The following is a description of a gene set: species: Mus musculus from publication Chen Y, Wang X (PMID 31504780) Genes predicted to be targets of miRBase v22 microRNA mmu_miR_107_5p in miRDB v6.0 with MirTarget v4 prediction scores > 80 (high confidence targets). Mouse Gene Set: MIR_107_5P, and this is the list of marker genes: Wsb1, Dipk2b, Naa30, Dusp3, Dolk, Alkal1, Fam120b, Cux1, Tada2b, Vps29, Phaf1, Tacr2, Slc6a15, Bbs10, Dyrk1a, Mtr, Cyld, Mtch2, Bmi1, Pwwp2a, Rgl1, Mysm1, Sigmar1, Ngef, Dnm3, Pitpnm2, Slc15a2, Lurap1l, Tbx2, Rspo3, Mctp2, Cdh11, Samd3, Mbnl2, Dach1, Gab2, Ginm1, Zbtb5, Pnma8b, Atrn, Tnpo1, Plcxd2, Ash1l, Gclm, Cdadc1 (NCBI Gene Id 71891), Rnpc3, Ammecr1, Ptprr, Cab39l, Cyct, Nr3c1 (nuclear receptor subfamily 3, group C, member 1), Stra6l, B230219D22Rik, St8sia3, Fam174a, Arsa, Itm2b, Grm7, Hccs, Ica1l, Dlc1, Rbm27, Bbx, Klhl24, Lipa, Prkaa2, Rcn1, Zbtb24, Ing5, Cdh12, Smarca4, Gpr82, Mab21l2 (NCBI Gene Id 23937), Micu3, Rala, Zfp827, Taf12, Pdzd2, Usp31, Rps15a, Man2a1, Mtmr1, Slc8a1, Ndst3, Thumpd3, Mef2c, Tmx2, Ankrd13b, Stx17, Hnrnpa2b1, Cbx6, Trak1, Nedd4l, Sec23ip, 1700066M21Rik, Tardbp, Slc38a2, Ipcef1, Nhsl2, Cdnf, Son, Fat3, Robo2, Susd6, Nedd9, U2surp, Hyal6, Slc17a8, Tsc22d2, Galnt13, Grk3, Adar (NCBI Gene Id 99861), Tnrc6b, Rnf152 (NCBI Gene Id 320311), Pdgfd, Tor1a, Mkrn1, Lpcat2b, Cxcr2, Akap10, Il17rd, Nav1, Gria4, Rgs1